The following is a description of a gene set: Human Gene Set: HP_JAUNDICE Yellow pigmentation of the skin due to bilirubin, which in turn is the result of increased bilirubin concentration in the bloodstream. Jaundice studied in species Homo sapiens, and this is the list of marker genes: SPTBN1, ATP6AP2, IL2RG, HBB, PRPS1, CTCF, POLG, DZIP1L, IFIH1, POU2AF1, DGUOK, SLC2A1, ABCD3, HYOU1, TRHR, TFAM (transcription factor A, mitochondrial), ALDOB, MTR, DUOX2, SLC25A13, PEX10, PEX5, CASK, LYN, KIF23, POU1F1, BRCA1, ARL13B, SLC44A1, AKR1D1, GPR35, JAK2, BRCA2, PKHD1, CCDC115, TSHR, YARS1, SMPD1, UNC45A, PRKAR1A, JAG1, PEX13, VIPAS39, CPOX, USP53, RNASEH2C, GALT, SLC51B, LSM11, KIF12, IFT56, PEX19, SERPINA1, EPB41, SPTA1, GCLC, PRF1, NR1H4, CASR, RHAG, SPINK1, MMEL1, PEX3 (NCBI Gene Id 8504), CDIN1, NAA10, PTPN3, UNC13D, ETFDH, NPC2, F5, PEPD, KMT2E, PRSS2, CPA1, TCF4, HNF1B, CYP7B1, GYPC, KCNN4, ATP6AP1, MED12, PEX26, CA5A, ACADVL (NCBI Gene Id 37), LHX3, DPAGT1, ETFB, COX4I2, IARS1, SLC10A1, LPL (NCBI Gene Id 4023), ABCB4, SEMA4D, SLC26A4, HESX1, GALE, CYP27A1, LRP5, SCO2, APC2, DUOXA2, SP110, FOCAD, TRPV6, KRT18, CDAN1, IL12A (NCBI Gene Id 3592), MPV17, CLDN1, UGT1A1, ATP7A, PRKCSH, SPIB, TPO, SLCO1B3, SLC37A4, G6PD, KRAS, BAAT, DEF6, GALK1, PALLD, NBAS, PAX8, DHFR, KYNU, POLG2, PEX16, NKX2-1, SKIC3, ATP7B, PARS2, RAB27A, UROS, IER3IP1, NSD1, RNASEH2A, SLC16A2, FLI1, TREX1 (three prime repair exonuclease 1), FCGR3B, GPI, HSD3B7, TRMU, COG7, LHX4, NKX2-5, PIEZO1, PALB2, PEX11B, PKLR, RHCE, ABCC2, PFKM, TG, HK1, TNFSF15, IYD, GALM, MYO5B, SAMHD1, PEX12, CFTR, HBG2, STXBP2, SMAD4, DCDC2, IRF5 (interferon regulatory factor 5), TPI1, PEX1, EIF2AK3, ALG6, AMACR, CALR, VPS33B, SPTB, IL18BP, SLC4A1, RNU4ATAC, TULP3, ADAR, STX11, EPB42, LBR, HTRA2, PKD2, SEC23B, MST1, PIGA, ETFA, TSHB, SLCO1B1, ANK1, RHD, IL12RB1, SLC30A10, PEX2, KMT2D, ADAMTS13, PRSS1, LYST, ZFYVE19, CTRC, HMGCL, ALDOA, RNU7-1, CDKN2A, RNASEH2B, FOXE1, TNPO3, GH1, ABCB11, SEC63, NPC1, ATP11C, PEX6, RINT1, OCLN, PROP1, SPOP, ATP8B1, TP53, RABL3, SLC5A5, LIPA, ROS1, MMACHC (metabolism of cobalamin associated C), TBX19, GLRX5, PEX14